The following is a description of a gene set: from publication Chen Y, Wang X (PMID 31504780) Mouse Gene Set: MIR_466C_5P species: Mus musculus Genes predicted to be targets of miRBase v22 microRNA mmu_miR_466c_5p in miRDB v6.0 with MirTarget v4 prediction scores > 80 (high confidence targets)., and this is the list of marker genes: Col15a1, Pfkfb2, Apol9b, Bclaf1, Hsd3b7, Nop58, Cplx4, Neurod1, Mbd5, Rab40c, Tmem200a, Cacnb4, Gabrg2, Abca9 (ATP-binding cassette, sub-family A member 9), Ap1s2, Mkrn1, Fmr1, Lats2, Bcor, Igfbp7, Diras2, Ppp2r1b, Dclre1c, Gabrb2 (NCBI Gene Id 78533), Cdca8, Zfp449, Msantd2, Cdkn1b, Slc35e2, Atad1, P2ry10b, Cap2, F11, Elmo3, Pdzd2 (PDZ domain containing 2), Kif15, Pxk, Vps35, Spdye4a, Mageb4, Mob4, Ppp2cb, Nek4, Ankrd28, Rbfox1, Gtf3c3, Ppm1b, Atad3a, Cnga4, Tnfrsf9, Rora, Sp1, Snrnp27, Epgn, Afap1l1, Robo2 (NCBI Gene Id 72126), Glo1, Bach2, Fez2, Muc15, Slc30a5, Usp8, Thbs2, AI987944